The following is a description of a gene set: Human Gene Set: HP_VENOUS_INSUFFICIENCY species: Homo sapiens Venous insufficiency, and this is the list of marker genes: ANGPT2, ENG, PIEZO1, PROS1, UFD1, GNAQ, KIF5A, FOXC2, PIK3CA, TGFB2, PROC (NCBI Gene Id 5624), GP1BB, CLCNKB, TBX1, SLC12A3, AEBP1, NDP, SEC24C, VHL, SLC29A3, JMJD1C, NOTCH3 (notch receptor 3), EPHB4, RASA1, COL3A1, G6PC3, SMAD3, SMOC1, ARVCF, GJC2, FLT4, FIBP, RREB1, AGGF1 (angiogenic factor with G-patch and FHA domains 1), COMT, THBS2, GBA1, ATP7A, SMAD2, HIRA, PTEN